Given this list of marker genes Glycam1, Sirt1, Phc2, Pwwp3b, Kics2, Zfp91, Ccdc47, Dnajb2, Clip3 (CAP-GLY domain containing linker protein 3), Atp2c1, Sim2, Prdm6, Gpr152, Ebf1, Ubr3, Nfasc, Hmga2, Mapt, Epha7, Slitrk1, Slc39a2, Cox16, S2bpcox16 (NCBI Gene Id 105940408), Acadsb, Stox2, Zfp36, Vcan, Sugp1, Slc37a2, Extl2, Trabd2b, Tspyl5, Ovca2, Hmmr, here is a description of the gene set: Genes predicted to be targets of miRBase v22 microRNA mmu_miR_365_2_5p in miRDB v6.0 with MirTarget v4 prediction scores > 80 (high confidence targets). Mouse Gene Set: MIR_365_2_5P studied in species Mus musculus from publication Chen Y, Wang X (PMID 31504780)